Given this list of marker genes KPNB1, MAVS, TRAF6 (NCBI Gene Id 7189), RELA, E, TRIM25, RPS15A, NPM1, PPIH, IKBKE, SIKE1, RPS2, RPS5, RPS20, SERPINE1, SP1, TLR7, PPIG, RPS27A, BCL2L1, UBA52, M, IFIH1, RIGI, 3a, PCBP2, N, PKLR, KPNA2, PDPK1, SARS coronavirus, complete genome, PSMC6, 6, PPIA, RPS3 (NCBI Gene Id 6188), RPS27, SFN, TOMM70, PPIB, NFKB1, 8b, RPS6, EEF1A1, FAU, 1a, RPS13, YWHAZ, RPS3A, SFTPD, RPS27L, NPIPB3, UBB, RPS21, TRAF3, RPS28, RPS4X, STING1, UBE2I, RPS17, RPS11, RPS16, RPS10, RPS26, UBC, NFKBIA, SMAD3, TKFC, HNRNPA1, RIPK3, CAV1, 7a, RUNX1, YWHAB, RPS9, SMAD4, YWHAE, NLRP3, RPS14, YWHAG, RPS12, 3b, rep, RPS24, BST2, NMI (NCBI Gene Id 9111), RPS15, TBK1, RPS7, CASP1, 9b, PYCARD (PYD and CARD domain containing), YWHAQ, RCAN3, YWHAH, RPS8, FKBP1A, IRAK2, RPS29, RPS23, RPS18, 18S rRNA, RPS19, S, RPS25, EP300, RIPK1 (NCBI Gene Id 8737), ITCH, RPSA, RPS4Y2, IRF3, RPS4Y1, PALS1, here is a description of the gene set: Coronaviruses are a group of enveloped viruses with single‑stranded, positive‑sense RNA genomes. Each of the steps of viral replication - attachment and entry, translation of viral replicase, genome transcription and replication, translation of structural proteins, and virion assembly and release - involves host factors. These interactions can cause alterations in cellular structure and physiology, and activate host stress responses, autophagy, cell death, and processes of innate immunity (Fung TS & Liu DX 2019). Reactome Pathway: SARS-CoV-1-host interactions species: Homo sapiens part of: SARS-CoV-1 Infection